The following is a description of a gene set: Human Gene Set: HP_APLASIA_HYPOPLASIA_OF_THE_EARLOBES Aplasia/Hypoplasia of the earlobes species: Homo sapiens Absence or underdevelopment of the ear lobes., and this is the list of marker genes: ARVCF, JMJD1C, SEC24C, HBA1 (NCBI Gene Id 3039), B4GALT7, FGFR2, PTPRF, HNRNPH1, NUP85, RBBP8, SCARF2, ATRIP (ATR interacting protein), PCNT, HIRA, RREB1, KCTD1, COL3A1, CREBBP, CHD7, FLI1, SEMA3E, SLC35C1, ESCO2, EP300, KMT2B, UFD1, HBA2, COMT, FN1 (NCBI Gene Id 2335), TBX1, RBM10, GP1BB, CEP152, COL2A1, ZMYM2, PLK4, HMX1, POLR3A, SMS, KAT6A, TRAIP, SMAD4, FIG4, DNA2, ABHD5, EBF3, AHDC1, ATR, VPS13B, CDC6, RNU4-2 (NCBI Gene Id 26836), CENPE, ZNF407